Given this list of marker genes FZD6, ALS2CL, NXPH1, H4C6, UCHL5, RPGRIP1, KIF18A, THRSP, MFGE8, JAG1, TLE1, CTNNAL1 (NCBI Gene Id 8727), CAP1, CD36, RND3, SHCBP1, EFHD2, REEP3, POLD1, ZFP28, CLSPN, UGT8, ACSL3 (NCBI Gene Id 55484), ANGPT1, ST6GAL2, PRXL2B, NUSAP1, TMEFF2, BUB1 (NCBI Gene Id 699), ASPM, PRKAR1B (protein kinase cAMP-dependent type I regulatory subunit beta), MCM5, RCC1, ASPH (aspartate beta-hydroxylase), INCENP, SDC4, CTNNBIP1, PLLP, CSF2RA, RRM1, COL4A6, CCNB2 (cyclin B2), GPM6A, RNF128, CTSV, SPARCL1, NAT8, C4B, MAD2L1, CENPQ, CDC20, MMP15, CITED1, PLK4, MT1X (metallothionein 1X), DPYSL4, CDT1, EPHB2, NASP, SMC2 (NCBI Gene Id 10592), CPLX2, SERPINB6, ANLN, CD38, GCAT, HSPB8, RFC4, PDPN, GNAO1, BEX1, MCM4, CDCA3, LIG1, ETV4, CLU, CDCA8, NDC80, CCNB1, UPP1, BHLHE22, NUF2, TUBB3, TRIB2, SNX18, RAD54L, LMNB1, CD24, SPRY1, CIT, PCLAF, GPD1, WNT7A, BCAS1, CKS2, CPPED1, DUT, RACGAP1, SPSB4, C1orf198, ECT2, RAD51AP1, CDKN2A, ASS1, GPR137B, PTPRD (NCBI Gene Id 5789), FBLN2, PIK3R3, CKS1B, MCM2, PLA2G7, TRIM2, ACOT7, MBP, CADM2, ROBO2 (roundabout guidance receptor 2), MAPK1IP1L, APLP1, RRM2, TMEFF1, PPP2R2B, CNIH2, F3, EDNRB, FBXO32, NUP107, RAD51, JMJD8, SGO2, CSDC2, SH3BP4 (SH3 domain binding protein 4), SDK2, DDX39A, NUPR1, TK1, HELLS, MIS18BP1, FEN1 (flap structure-specific endonuclease 1), CRLF1, RLBP1, CCND1, POLA1, BIRC5, IER3, RBL1, UHRF1, SYT4, CEBPA, ECRG4, TDRD7, UNC5C, BMPER, ALDH1L1, PDGFRA, SMOC1, FLOT2, TOP2A, KIF22, VAT1L, CCNF, ETV5, RAB33A, PFKP, MYO1B, CENPN, EXO1, SOCS2 (suppressor of cytokine signaling 2), PAQR8, PRC1, AURKA, PLK1, POLE (DNA polymerase epsilon, catalytic subunit), RTL8C, CLDN11, E2F7, CA3, MXRA8, USP1, NES, PSD, NRCAM, CDC45, OTX2, DBF4, RBP1, LYN, IGFBP4, METRN, SPC25, HFE, KIF4A, SCG3, SCN1B, TAGLN3, TUBA4A, A2M, AURKB, VWA1, LHFPL2, TRIM62, SLC6A6, DUSP6, SLC6A11, LRRFIP1, FIGNL1, MTHFD2, CHRDL1, NCDN, GPD2, GOLM1, ZNF367, RAB29, CCND2, TMOD1, UBE2T (ubiquitin conjugating enzyme E2 T), CPQ, CAMK2D, ATP9A, ADGRG6, CCN1, FBN2, IL13RA1, KIF23, SPP1, CP, CTPS1, PLPP3, DUSP4, MCM3, TIMP4, DECR1, CPNE8, CHL1, BMPR1B, TESC, SEMA3A, SPAG5, SPRY4, GABRB1, VXN, VWC2, HOPX, MCM6, MELK, CD302, LSM12, RASSF3 (NCBI Gene Id 64500), OMG, TPX2, HIP1 (huntingtin interacting protein 1), here is a description of the gene set: The glioblastoma multiforme (GBM) plasticity signature: genes up-regulated in neural stem cells (NSC) with double knockout of TP53 and PTEN vs those with knockout of TP53 alone. Glioblastoma (GBM) is a highly lethal brain tumour presenting as one of two subtypes with distinct clinical histories and molecular profiles. The primary GBM subtype presents acutely as a high-grade disease that typically harbours mutations in EGFR, PTEN and INK4A/ARF (also known as CDKN2A), and the secondary GBM subtype evolves from the slow progression of a low-grade disease that classically possesses PDGF and TP53 events. Here we show that concomitant central nervous system (CNS)-specific deletion of p53 and Pten in the mouse CNS generates a penetrant acute-onset high-grade malignant glioma phenotype with notable clinical, pathological and molecular resemblance to primary GBM in humans. This genetic observation prompted TP53 and PTEN mutational analysis in human primary GBM, demonstrating unexpectedly frequent inactivating mutations of TP53 as well as the expected PTEN mutations. Integrated transcriptomic profiling, in silico promoter analysis and functional studies of murine neural stem cells (NSCs) established that dual, but not singular, inactivation of p53 and Pten promotes an undifferentiated state with high renewal potential and drives increased Myc protein levels and its associated signature. Functional studies validated increased Myc activity as a potent contributor to the impaired differentiation and enhanced renewal of NSCs doubly null for p53 and Pten (p53(-/-) Pten(-/-)) as well as tumour neurospheres (TNSs) derived from this model. Myc also serves to maintain robust tumorigenic potential of p53(-/-) Pten(-/-) TNSs. These murine modelling studies, together with confirmatory transcriptomic/promoter studies in human primary GBM, validate a pathogenetic role of a common tumour suppressor mutation profile in human primary GBM and establish Myc as an important target for cooperative actions of p53 and Pten in the regulation of normal and malignant stem/progenitor cell differentiation, self-renewal and tumorigenic potential. studied in species Mus musculus Human Gene Set: ZHENG_GLIOBLASTOMA_PLASTICITY_UP from publication Zheng H, Ying H, Yan H, Kimmelman AC, Hiller DJ, Chen AJ, Perry SR, Tonon G, Chu GC, Ding Z, Stommel JM, Dunn KL, Wiedemeyer R, You MJ, Brennan C, Wang YA, Ligon KL, Wong WH, Chin L, DePinho RA (PMID 18948956)